The following is a description of a gene set: DNA replication Human Gene Set: WP_DNA_REPLICATION species: Homo sapiens, and this is the list of marker genes: ORC1 (NCBI Gene Id 4998), POLD4, MCM10, RFC2, POLD2, MCM2, ORC4, ORC5, MCM5, CDT1, RFC4, UBA52, GMNN, CDC7, RPA2, ORC2, POLE2, POLA2, POLE, PRIM2, MCM7, MCM4, CDK2, RPA4, RPA3, DBF4, MCM6, RFC3, MCM3, RFC1, CDC45, ORC3 (origin recognition complex subunit 3), RPA1, PCNA, PRIM1, POLD1 (NCBI Gene Id 5424), POLD3, UBC, ORC6, RFC5 (replication factor C subunit 5), POLA1, CDC6